The following is a description of a gene set: Mouse Gene Set: GOBP_NEGATIVE_REGULATION_OF_AMYLOID_BETA_CLEARANCE studied in species Mus musculus Any process that stops, prevents or reduces the frequency, rate or extent of amyloid-beta clearance., and this is the list of marker genes: Tnf, Myocd, Ifngr1, Lrpap1, Pla2g3, Ifng, Srf, Hmgcr, Cyp51